The following is a description of a gene set: species: Mus musculus Deactivation of the beta-catenin transactivating complex Mouse Gene Set: REACTOME_DEACTIVATION_OF_THE_BETA_CATENIN_TRANSACTIVATING_COMPLEX, and this is the list of marker genes: Tcf7, Tle4, Sox4, Ctnnb1, Tcf7l2 (NCBI Gene Id 21416), Ctnnbip1, Ywhaz, Ctbp1, Ubc, Sox13, Tle2, Tcf7l1, Tle1, Uba52rt, Lef1, Akt2, Sox9, Sox6, Ubb, Tle3, Sox17 (SRY (sex determining region Y)-box 17), Xiap, Chd8, Xpo1, Sox3, Uba52, Rps27a, Akt1, Apc, Cby1, Hdac1, Sox7 (SRY (sex determining region Y)-box 7)